The following is a description of a gene set: Any process that results in a change in state or activity of a cell (in terms of movement, secretion, enzyme production, gene expression, etc.) as a result of a reactive oxygen species stimulus. Reactive oxygen species include singlet oxygen, superoxide, and oxygen free radicals. species: Homo sapiens Human Gene Set: GOBP_CELLULAR_RESPONSE_TO_REACTIVE_OXYGEN_SPECIES, and this is the list of marker genes: CAT, MB, CRYGD, FBLN5, FOS, BNIP3, PEX14, PLEKHA1, MAPT, SOD2, ERN1 (NCBI Gene Id 63433), CYP1B1, SPHK1, HSF1, AQP1, PXN, MYB, GPR37L1, CFL1, MIR107, PJVK, GATA5, NOS3, AMBP, CCS, PRDX1, TRPM2, CYGB, MIR133A1, NME8, PPP5C, MAP2K4, APOA4, KDM6B, TET1, TXN, MIRLET7B, ABL1, MAPK7, PEX12, CDK1, RIPK1, ANKZF1, TRPA1, RIPK3, DHFRP1, KLF2, PRDX3, MPO, PEX13, SLC8A1, MAPK13, SETX, PDGFRA, FOXP1, TRAP1, PRKAA1, FXN, CD36, LRRK2, AIFM1, FOXO3, MIR17, TOP2B, IL18BP, ENDOG, PCGF2, ZNF277, ZNF580, SOD1, OGG1, ROMO1, ATM, AGAP3, HDAC2, CAMKK2, PEX2, RPS3 (ribosomal protein S3), SOD3, IL6, NPPA, PPIF, ECT2, RHOB, STK25, MIR103A1, TRPC6, SIRPA, NQO1, PRKCD, TNFAIP3, PINK1, PEX5, MIR92A1, MAP3K5, PEX10, GCH1, SMPD3, PDCD10, MAP1LC3A, CDKN2A, IL18RAP, HDAC6, SIRT1, MDM2, SRC, ADPRS, MIR21, TREX1, PRDX2, PKD2 (NCBI Gene Id 5311), BMP7, GPR37, MAPK8, PDGFD, BTK, BECN1, MIR34A, FABP1, FYN, CBX8, PTPRK, ERCC6L2, PAWR, NFE2L2, PARK7, PDK2, RELA, PRDX5, EDN1, DHFR, FER, DDR2, NET1, MAPK9, MMP2, RACK1, MET, HGF, MMP3, UCP1, TPM1, PPEF2, PCNA, LCN2, AKT1, EZH2, MPV17, KLF4, OSER1, ATP7A, MT3